The following is a description of a gene set: Mouse Gene Set: GOBP_VITAMIN_D_METABOLIC_PROCESS studied in species Mus musculus The chemical reactions and pathways involving vitamin D, any of a group of related, fat-soluble compounds that are derived from delta-5,7 steroids and play a central role in calcium metabolism. Specific forms of vitamin D include calciferol (ergocalciferol; vitamin D2) and cholecalciferol (calciol; vitamin D3)., and this is the list of marker genes: Lrp2, Fgf23, Enpp1, Gc, Cyp27b1, Gfi1, Fgfr4, Snai1, Cyp24a1, Nfkb1, Snai2, Cyp27a1, Tnf, Cyp2r1, Ifng, Fgfr1